Given this list of marker genes Gm9463, Gm38430, 3300002P13Rik, Vmn1r88, Vmn2r-ps45, Gm19093, Vmn1r86, Vmn1r67, Ncr1, Vmn2r33, Vmn1r-ps60, 4933431C10Rik, Gm51440, Vmn1r89, Tnnt1, Obox4-ps17, Gm30645, Tmem167-ps1, Gm5320, Galp, Gm9652, Rps5, Gm4224, Prkcg, Gm19201, Tsen34, Sult2a4, Gm6855, Tpt1-ps4, Gm3675, Vmn2r41, Gm29708, Vmn1r-ps55, Zscan5b, Vmn1r-ps63, Kmt5c, Vmn1r65, Vmn1r68, Aurkc-ps, Sbk2, Gm3962, Gm45631, Obox4-ps39, Atp6v0c-ps1, Vmn2r46, Vmn2r37, Garin5b, Gm45844, Obox4-ps10, Vmn2r-ps44, Nlrp2, Gm20553, Gm6946 (predicted gene 6946), Tmem190, Zim3, Brsk1, Gm15927 (predicted gene 15927), Gm18205, Vmn1r-ps51, Vmn2r32, Pafah1b1-ps2, Il11, Rpl28, Gm7151, Gm18198, Obox3-ps7, Zfp580, Gm7210, Zfp784 (zinc finger protein 784), Gm15923, Tfpt, Vmn1r87, Gm7363, Gm3189, Vmn1r-ps62, Vmn1r77, Eps8l1 (NCBI Gene Id 70195), Tnni3, Zscan4a, Gm18973, Rfpl4, Gm19683, Zfp78, Nlrp4b, Gm7696, Gm45549, Zfp419, Zscan4c, Zscan18, Rnf225, Zscan4-ps2, Gm15926, Zbtb45, Zscan4d, Mir290a, Gm17850, Obox4-ps16, Gm5996, Ssc5d, Vmn2r-ps42, Gm23741, Tarm1, Ttyh1, Vmn1r59, Obox7, Gm6727, Vmn1r-ps40, 1700095K22Rik, Gm34779, Vmn1r66, Zfp446, Vmn1r57, Cnot3, Gm18122, Nlrp4d, Nlrp5-ps, Vmn1r56, Gm7651, Zfp128, Vmn1r-ps56, Gm26056, Gm6850, Pla2g4c-ps, Sbk3, Vmn2r35, Vmn2r-ps47, Obox4-ps7, Zfp773, Gm5321, Gm3623 (NCBI Gene Id 100042009), Clcn4, Zim2, Gm7839, Vmn2r38, Gm3702, Vmn2r-ps49, Rps8-ps4, Vmn1r85, Zswim9, Gm3978, Vmn2r50, Lilra6, Myadm, Gm38947, Or10am5, Zfp418, Vmn1r72, Mzf1, Gm38941, Gm3375, Gm5340, Vmn2r30, Gm15510, Usp29, Vmn1r-ps67, Ube2m, Gm7836, Gm7353, Gm45351, Cdc42ep5, Zfp582, Leng8, Gm4903, 2810047C21Rik1, Obox4-ps37, Vmn1r60, Gm20482, Zfp787, Vmn2r28, Tmem238 (transmembrane protein 238), Vmn2r34 (vomeronasal 2, receptor 34), Cox6b2, Gm18204, 9430041J12Rik, Olfr1345-ps1, Vmn1r80, Zscan4b, Oscar, Lair1, 2410039M03Rik, Vmn2r-ps46, Gm3611, Gm3836, Zfp865, Pira2-ps1, Pla2g4c, Gm15928, Gm18124, Cacng6, Obox4-ps36 (NCBI Gene Id 106780820), Gm18638, Gm7789, Gm9689, Obox4-ps38, Mboat7, Pira13, Cabp5, Gm7587, Or2bd2, Tmem150b (NCBI Gene Id 330460), Gp6, Gm18757, Cacng8, Nat14, Trim28, Gm44451, Vmn1r-ps65, Gm3584, Ptprh, Vmn2r45, Vmn2r49, Vmn2r-ps51, Lilra5, Syt5, Cacng7, Mir291b, Vmn2r55, Vmn2r56, Sult2a5, Vmn2r-ps38, Gm6828, Pira2-ps2, Gm3665, Mir3572, Obox4-ps3, Sult2a3, Vmn1r61, Zfp628, Gm3563, Or6z3, Vmn1r82, Gm6929, Gm6900, Gm7965, Sult2a6 (NCBI Gene Id 629219), Obox4-ps2, Vmn1r90, Gm3956, Eddm13, Mir292, Vmn2r29, Zfp524, Chmp2a, Vmn1r73, Gm18190 (predicted gene, 18190), Mrps36-ps3, Vmn2r-ps40, Obox3-ps2 (NCBI Gene Id 666312), Gm10179, Gm47692 (NCBI Gene Id 108167472), Kat6b-ps1 (K(lysine) acetyltransferase 6B, pseudogene 1), Zscan4-ps3, Gm24537, Pira2, Vmn1r58, 1810019N24Rik, Zscan4-ps4, Or6z1, Gm20679, Gm20287, Gm33601, Obox4-ps15, Obox4-ps4, Vmn2r-ps41, Gm18597, Zscan4-ps1, Obox4-ps1, Gm18850, Obox3-ps1, Or5bw2, Vmn2r-ps36, Gm45401, Gm10693, Zscan4f, Gm18201, Vmn1r74, Vmn2r40, Gm45598, Vmn1r75, Vmn2r-ps52, Smim17, Hspbp1, Rdh13, Mir3099, Vmn1r-ps64, Gm6909, Vmn1r55 (vomeronasal 1 receptor 55), Zfp772, Shisa7, Mir5620, Gm15931, Isoc2a, Gm7648, Obox3-ps3, Sult2a-ps1, Vmn1r-ps50, Bsph1, Obox4-ps11, Gm3816, Zscan22, Vmn1r84, Ranbp2-ps2, Vmn2r39, Gm3585, Obox4-ps13, Gm3726, Vmn1r62, Nlrp12, Zfp264, Gm3654, Gm5583, Gm18200 (NCBI Gene Id 100416696), Sult2a-ps2, Mir290b, Obox3-ps4, Zbed4-ps1, Fiz1, Gm3912, Zfp28, Zim1, Gm39481, Speer9-ps1, Tmem167-ps2, Vmn1r-ps66, Vmn2r42, Zscan4e, 4933402C05Rik, Pirb, Obox4-ps8, Vmn1r-ps47, Sult2a1, Vmn2r44, Vmn1r63, Lig1, Gm7786, Prpf31 (NCBI Gene Id 70126), Obox4-ps5, Gm44254, Vmn1r81, Vmn2r31, Gm18123, Vmn1r71, Gm26325, Vmn1r-ps45, Sult2a7, Zfp329, Gm38944, Gm35037, Gm7848, Vmn2r52, AU018091, Tmc4, Or6z6, Tmem86b (NCBI Gene Id 68255), Vmn2r-ps37, Gm36371, Vmn2r43, Ppp6r1 (NCBI Gene Id 76753), Gm6842, Or6z5, Rasl2-9, Gm3104, Pira12, Sult2a2, Vmn1r69, Mir293, Leng1, Gm15877, Gm3774, Mir935, Vmn1r-ps61, Vmn1r-ps52, Ccdc106, Gm18781, Gm15773, Gm4247, Vmn1r-ps68, Sult2a-ps4, Vmn2r48, Gm31152, Gm18854, Vmn1r-ps59, Zfp606, Gm5319, Zik1, Gm18641, Slc27a5, Rpl7a-ps14, Obox4-ps9, Gm18851, 2700052C19Rik, Zfp324, Pira1, Obox4-ps6, Sult2a8 (sulfotransferase family 2A, dehydroepiandrosterone (DHEA)-preferring, member 8), Peg3, Phf20-ps, Bsph2, Mir295, Lgalsl2, Zfp551 (zinc finger protein 551), Vmn1r78, Vmn1r-ps49, Nlrp4c, Gm36210, Ndufa3, Isoc2b, Vmn1r-ps58, Vmn2r53, Zfp579, Gm4073, Tmem167-ps3, Gm18199, Leng9, Zbed4-ps2, Gm18194, D030047H15Rik, Vmn1r83, Rpap3-ps2, Rps9, Vmn1r64, Gm3616, Gm45596, Vmn2r54, Gm9604, Mir294, Vmn2r-ps53, 2900092C05Rik, Gm4270, Gm7230, Epn1, Gm18193, Mir291a, Ppp1r12c, Vmn2r-ps35, Obox4-ps12, Zfp444, Vmn2r36, Gm5130, Vmn1r-ps48, Or6z7, Vmn1r-ps57, Obox4-ps14, Vmn1r-ps69, Gm7203, Zbed4-ps3, Vmn2r51, Gm18639, Zfp110, Gm18191, Vmn1r-ps46, Gm18640, Gm4157, U2af2, 1700047O18Rik, Dnaaf3, Ube2s, Gm4879, Vmn2r47, Vmn1r70, Zfp667, Vmn1r76, Vmn2r-ps43, Zfp583 (NCBI Gene Id 213011), Gm4011, Mir292b, Zfp954 (zinc finger protein 954), Obox8, Kat6b-ps2, Vmn1r79, Vmn1r-ps53, Aurkc, here is a description of the gene set: studied in species Mus musculus Mouse Gene Set: chr7A1